The following is a description of a gene set: Human Gene Set: GOBP_REGULATION_OF_SMOOTHENED_SIGNALING_PATHWAY Any process that modulates the frequency, rate or extent of smoothened signaling. species: Homo sapiens, and this is the list of marker genes: TTBK2, EFCAB7, PTCH2, ISL1, GLIS2, POR (NCBI Gene Id 96440), CREBBP, RACK1, TMED2, GAS1, SKOR2, INTU (inturned planar cell polarity protein), DYNC2H1, IFT122, IFT81, GAS8, GPR37L1, ARMC9, FGFR2, SMO, CHSY1, VCP, HHIP, TEDC2, SCUBE1, CDK20, TTC21B, IFT140, GPC3, HERC4, GPR161, ULK3, OTX2, RUNX2, ENPP1, KCTD21, TUBD1, FGF10, RB1, PRRX1, NCOA2, TRAF3IP1, DCDC2, CPLANE2, RORA, ZIC1, FUZ, GLI1, CTNNA1 (catenin alpha 1), KIF7, TEDC1, NDST1, TTC23, CIBAR1, UCHL5, C2CD3, ARL6, RFX4, MEGF8, IHH, GLI3, BTRC, IFT172, SHH, EVC, PRKACB (NCBI Gene Id 5567), DHH, FBXL17, SFRP1, MOSMO, MGRN1, PTCH1 (NCBI Gene Id 8015), UBR5, ACTRT1, CD3E, TCTN1, SUFU, PDCL, FGF9, TULP3, RPGRIP1L, MKS1, TXNDC15, STK36, KCTD6, PRKACA, SERPINE2, WDR11, SHOX2, RAB34, FOXA1, GORAB, KCTD11, DLG5